Given this list of marker genes Egfr, Btc, Areg, Tgfa, Epgn, here is a description of the gene set: This event has been computationally inferred from an event that has been demonstrated in another species.<p>The inference is based on the homology mapping from PANTHER. Briefly, reactions for which all involved PhysicalEntities (in input, output and catalyst) have a mapped orthologue/paralogue (for complexes at least 75% of components must have a mapping) are inferred to the other species. part of: Signaling by EGFR electronically inferred by orthology from the curated human pathway studied in species Mus musculus Reactome Pathway: EGFR interacts with phospholipase C-gamma